The following is a description of a gene set: studied in species Homo sapiens Malabsorption Impaired ability to absorb one or more nutrients from the intestine. Human Gene Set: HP_MALABSORPTION, and this is the list of marker genes: SRP54, POLE, IL23R, DKC1, IRF5, XRCC4, TRMT5, PTRH2, RMRP, MSH2 (mutS homolog 2), TLR4, CD79A, AK2, WFS1, CLMP, CYP7B1, TET2, CCN2, RFC2, CAV1, MYD88, AGA, SLC2A2, HMGCS2, UBAC2, IRF4 (NCBI Gene Id 4592), SLC9A3, PKHD1, KMT2D, EFL1, RECQL4, PEX1, CLCA4, RTEL1, GTF2I, SAA1, METTL27, ZBTB24, CEACAM6, HYOU1, AMACR, KDM6A, SLC46A1, PEX2, PEX10, ACOX2, PEX3, TREH, TBL2, PARN, PERCC1, CTC1, ABCB11, CIITA, CTNNB1 (catenin beta 1), KLRC4, FAT4, TINF2, PCSK1, USB1, CD79B, CYBC1 (cytochrome b-245 chaperone 1), BAZ1B, HSD3B7, MADD, SATB1, F5, GSTM3, TCF3, CLTRN, SPINK1, SLC39A4, NOP10, SHPK, BTK, PEX19, UHRF1, IGLL1, SPIB, BRCA2, ERCC2, EDNRA, APC, NHP2, PEX16, NEUROG3, IL12A, PIK3R1, LBR, ATP8B1, HMOX1, EPCAM, GTF2IRD1, FLNA (NCBI Gene Id 8272), ATM, FOXP3, TYMS, DZIP1L, ARX, MSH6, FKBP6, COX4I2, AIRE, RUNX1, PMS1 (PMS1 homolog 1, mismatch repair system component), HPGD, PGM3, GLA, FCGR2A, NCF2, HFE, SI, DSG1, SBDS, EIF4H, DNAJC30, SPINK5, RFX6, CD55, CDCA7, SPI1 (Spi-1 proto-oncogene), MUTYH, LIPA, ATP7A, STX1A, TERT, HLA-DQB1, HLA-DQA1, MPI, SLC6A14, CCR6, HELLS, LIMK1, IL10, MMEL1, CTRC, MLH1, ERAP1, FAS (Fas cell surface death receptor), CFTR, BLNK, ENPP1, ELN, SERPINA1, RPS20 (NCBI Gene Id 6224), NPM1, TNPO3, JAK2, PRSS1, PEX26, KCNN4, MTTP, NSUN2, POLD1, BMPR1A, PEX13, DMP1, SRSF2, LIG4, SLC11A1, PEX6, CYBB, STAT4, UBR1, CISD2, MCM6, ABCB4, GTF2IRD2, MIF, PNLIP, TGFB1, LRRC8A, CCBE1, PEX14, KRAS, SLC29A3, APOB, CYBA, PEX12, SLC26A9, IL12RB1, SLC7A7, TJP2, PTF1A, SEMA4A, ANTXR2, IFNGR1, OCRL, SLC51B, GCLC, DNAJC21, FOXN1, HLA-B, PIK3CA, POU2AF1, VPS37D, CHEK2, SLC10A2, MTOR, LCT, CEACAM3, SLCO2A1, PEX5, MEFV, CLIP2, AKR1D1, POLG, NCF1, TERC, SAR1B, WRAP53, CALR (calreticulin), TYMP, ASXL1, PMS2, DCTN4, ADAMTS3, SLC5A1, SLC39A7 (NCBI Gene Id 7922), CCDC47, CBL, IL12A-AS1, NCF4, DNMT3B, BUD23, LPIN2, TGFBR2, C4A (NCBI Gene Id 720), TNFSF15, TMEM270, IGHM (immunoglobulin heavy constant mu), PMM2, PEX11B, SLC6A19 (NCBI Gene Id 8062), CCR1, PRSS2, HLA-DRB1